Given this list of marker genes Fgf8, Fgf2, Fgf17, Fgf22, Fgf5 (NCBI Gene Id 14176, fibroblast growth factor 5), Fgf23, Fgf4, Fgf16, Fgf1, Fgf7, Fgf6, Fgf20, Fgfbp3, Fgf10, Fgfbp1, here is a description of the gene set: Reactome Pathway: FGFR2 ligand binding and activation This event has been computationally inferred from an event that has been demonstrated in another species.<p>The inference is based on the homology mapping from PANTHER. Briefly, reactions for which all involved PhysicalEntities (in input, output and catalyst) have a mapped orthologue/paralogue (for complexes at least 75% of components must have a mapping) are inferred to the other species. studied in species Mus musculus part of: Signaling by FGFR2 electronically inferred by orthology from the curated human pathway